Given this list of marker genes TUBGCP4 (tubulin gamma complex component 4), CDK5RAP2, TUBG1, TUBGCP5 (NCBI Gene Id 114791), NME7, MZT2B, MZT2A, TUBG2, MZT1, TUBGCP6, BRCA1, here is a description of the gene set: studied in species Homo sapiens Human Gene Set: GOCC_GAMMA_TUBULIN_RING_COMPLEX A complex of gamma tubulin and associated proteins thought to be formed by multimerization of gamma-tubulin small complexes. An example of this structure is found in Schizosaccharomyces pombe.